The following is a description of a gene set: studied in species Homo sapiens Genes up-regulated in comparison of naive CD4 CD8 T cells versus unstimulated memory CD4 CD8 T cells. Immune cell-specific expression is one indication of the importance of a gene's role in the immune response. In order to identify such patterns, we set out to broadly profile gene expression in a variety of immune cells. Human Gene Set: GSE22886_NAIVE_VS_MEMORY_TCELL_UP from publication Abbas AR, Baldwin D, Ma Y, Ouyang W, Gurney A, Martin F, Fong S, van Lookeren Campagne M, Godowski P, Williams PM, Chan AC, Clark HF (PMID 15789058), and this is the list of marker genes: OVGP1, GOLGA8H, PDE1B, CRCT1, ZNF721, NOL6, SLC10A1, PNPLA4, VPS52, TLE5, KAT7, COL6A1 (collagen type VI alpha 1 chain), FOXH1, TRMT44, TLE1, DNMBP, ACTN1, IRAG2, GSAP (NCBI Gene Id 54103), CASR, NPFFR1, TSR1, SLC16A10, AQP6, FOXC1, SERPINF1 (NCBI Gene Id 5176), PTPRO, ATP8B1, POLR3E, IPP, ELOA, GUSBP3, ADAP1, VPS11, PHLDA1, TCTA, SBNO1, PLXDC1, SEMA4G, ADGRA3, CYP2A13, FEZ1, PRKAR1B, ST14, ASCC1, ERCC3, CARD9, ZNF148, AKAP9, PARP16, NOTCH2NLA, PDX1, TFDP2, DAPK2 (death associated protein kinase 2), CD79A, PHF20L1, DMWD, NLGN3, DCTN6, NPFF, ZG16, ENOSF1, ST3GAL2, SLC5A3 (NCBI Gene Id 6526), GRIK5, FMO2, CACNA2D2, HSP90AB1, CEP152, PDE4C, SLC25A17, ZNF771, GTF2H3, RPGR, CD55, PLCXD1, HNF1B, ZNHIT2, SSBP3, XDH, BEND5, SLC25A37, PIEZO2, PLEKHA4, MIER2, UBQLN4, TRIOBP, UPK2, CLDN15, PINK1, FOXA2, PRELID3A, NLRX1, YJU2B, RBM41, CYP3A4, PECAM1, TLL2, SPACA9, FBP1, GREB1, TMEM80, PPT2 (NCBI Gene Id 9374), JRK, PDGFRB, HOXB9, SULT2B1, CLUH, SH3BP2 (NCBI Gene Id 91018), ZMYND8, DSC1, RAX, MYB, CORT, NOP16, TMED1, VNN2, KIAA0753, EVX1, KCNMA1, BTN3A1, CDK14, EPN3, SCN1B, ALMS1, SNIP1, HOMER1, WASF1, ANAPC1, SEMA6C, SLC35E1, ALKBH4, SCN2B, PTCD2, IFNGR2, HLA-DMB, PKD1P1, TCF7, DCLRE1C, ACSF2, PUS7L (NCBI Gene Id 83448), TBKBP1, CCHCR1, NOTCH1, PGF, ARHGAP33 (Rho GTPase activating protein 33), PAK3, MAPRE2, GOLGA2, SYNGR1, DYNC1LI2, MTPAP, FAM3A, PHF1 (NCBI Gene Id 5252), COA1, ACTN2, HPSE2, LRRN3, ECHDC2, NDE1, SATB1, ATM, CACNB4, HAUS2, DCP1A, TCF3, BTK, SNED1, CDKL2, MPHOSPH9, ZNF292, HAPLN2, SEC31B, ZNF428, GNG7, LINC00652, EGR4, POLM, NUMA1, POLR1B, DBT, CABIN1, ACACA, CBX8, SREBF1, REC8, PIAS4 (protein inhibitor of activated STAT 4), MAPK8IP3 (mitogen-activated protein kinase 8 interacting protein 3), ZDHHC24, CEP250, TNPO2, RBM12B, CCDC28B, FXYD2